The following is a description of a gene set: Human Gene Set: HP_LONG_PHILTRUM Long philtrum species: Homo sapiens Distance between nasal base and midline upper lip vermilion border more than 2 SD above the mean. Alternatively, an apparently increased distance between nasal base and midline upper lip vermilion border., and this is the list of marker genes: ACTB, FZD2, SMG8, SATB2, CANT1, KAT6B, CEP290, KIAA0753, UBAP2L, MADD, PDPN, LUZP1, ARHGEF2, SLC9A7, HES7, ALG9, USP9X, ATP6V0A2, BRD4 (NCBI Gene Id 90616), AARS1, PLAA, MYCN, POU4F1, ARX, TMEM70, MAB21L1, MYH3, PUF60, ELN, RIN2, TBC1D20, MYO18B, STAG2, SLC4A10, EXOSC1, RPL10, CHRNG, AFF4, MEIS2, DYNC2I2 (NCBI Gene Id 89891), PEX26, TBCE, B4GALT1, TAF8, IDH1, PIEZO2, CRLF1, IFT74, MTOR, WDPCP, VPS37D, PCLO, CCDC8, CASZ1, TET3, TRIP12, EIF2S3, USB1, DLK1, MID1, PKDCC (protein kinase domain containing, cytoplasmic), ATP6V1A, ADSL (adenylosuccinate lyase), KIF26A, AP2M1, POC1A, EXTL3, RFX7, LTBP3, NF1, ATP7A, ACTA1, TAF6, PPP2R3C, TBL2, COG3, DYNC2I1, FBN1, TRPS1, ACTG1, UBE4B, OCLN (NCBI Gene Id 4950), MAB21L2, OTUD6B, CAMTA1, NEK9, H3-3A, CFAP418, BRCC3, SCAF4, NPHP1, CHST3, SC5D, NRAS, ATN1, RIPPLY2, TBX5, RAC3, ARVCF, SLC2A1, BRPF1, THSD1, SCAPER, PIGT (phosphatidylinositol glycan anchor biosynthesis class T), ANTXR1, KCNH1, PYCR1, CEP19, PPP1CB (protein phosphatase 1 catalytic subunit beta), CLCF1, EXOC7, MAPK1 (NCBI Gene Id 5594), RREB1, FOXP2, IRX5, SMARCB1, SKIC3, UFD1, METTL23, CNOT1, WWOX, COL2A1, ARID1A, SCLT1, LZTR1, MAPRE2, ADNP, CDC6, CHD2, HRAS, RERE, JMJD1C, ALDH6A1, AVP, CASK, SLC25A24, MAPK8IP3, INPPL1, ZC4H2, AHDC1, RFC2, PTH1R, TBX1, FAR1 (NCBI Gene Id 84188), DDR2, PTCH1, DVL3, TNNI2, TOR1A, BCOR, BUB1B, NBAS, PIGQ, BBS2, CCNK, IFT172, UBR1, OBSL1, SEC23A, DHCR7, KARS1, ALG8, PCDHGC4, NIPBL, SDCCAG8, TBC1D24, CDK10, COX7B, YARS2, KIF7, GNPTAB, APC, IFT27, CLTC, PRKDC, HIRA, ARL6, GLB1, PMM2, PTEN, MYOD1, POLR3A, FILIP1, BMP1 (NCBI Gene Id 649), MEG3, AP3B1, GLIS3, TPM3, NLRP1, CLCN3, KIF11, SPRED2, NEXMIF, ARID1B, RAP1B, NAA10, KMT2A, BRAT1, PYCR2, PRDM16, FGFR2, TBCK (TBC1 domain containing kinase), MYMX, NOTCH2, FGFR1, GABRD, KCNAB2, SLC2A10, GNE, PLPBP, ALG13, FLI1, ZMIZ1, PHIP, GJA5, PPP1R21, MMP23B, B3GLCT, MAF, MAP2K1, TTC5, EPG5, RAD21, CLIP2, CD96, TNPO2, ATP6V1B2, SEC24C, LTBP1, H3-3B, KIT, RIC1, NXN, NSRP1, IGF1R (insulin like growth factor 1 receptor), COL11A1, MGAT2, MUSK, BUD23, ADAMTSL2, RAI1, XYLT1, KRAS, PGM2L1, MESP2, STX1A, SNRPB, CDH2, SLC6A1, BAP1, TMEM270, BBS5, EXT2, ARSK, MKS1, KDM4B, ERCC6, WNT5A, LTBP4, SRCAP, ATP6V1E1, CRTAP, EXT1, BAZ1B, NFIB, PIGB, SETD5, DSE, TRIP11, ABCC8, TENM3, KCNJ11, EXOC2, GJA8, DYNC2H1 (NCBI Gene Id 79659), EIF4H, MTX2, CTCF, BBS1, CREBBP (NCBI Gene Id 1387), NALCN, BBIP1, MOCS1, GP1BB, MAP3K7, HMBS, KLHL41, PIGN, METTL27, LFNG, SKI, SYNE1, MPC1, SMARCA2, CSGALNACT1, FLNA, XYLT2, FGF3, NCF1, COG1, GTF2IRD2, SETBP1, WDR35, MLXIPL, BMP2 (bone morphogenetic protein 2), CDH11, UGP2, EFEMP1, CTNNB1, TMEM94, RAB3GAP2, LIMK1 (NCBI Gene Id 3984), AP1G1, SLC6A17, POR, SPECC1L, EZH2, TMEM53, SLC26A2, BBS7, PAH, PPP2R5D, COL11A2, CLCN6, SMC1A (structural maintenance of chromosomes 1A), SPEN, KCNJ8, BRF1, HSPG2, SUZ12, MKKS, SNX14, PDHA1, HPDL, SLF2, BCL11B, TUBB, SMOC1, BBS4, RNU4ATAC, B3GAT3, SIN3A, IFT81, FGD1, HUWE1, GTF2IRD1, NSD2, MARS2, NEB, BMP4, MED12, ZFX, LZTFL1, PDE4D, CBL, MYMK, BBS9, SHMT2, TMEM147, ROR2, WARS2, PRMT7 (protein arginine methyltransferase 7), SHANK3, TRIM32, COMT, PPP1R15B, DBR1, HECTD4, OSTM1, UBR7, TASP1, EXOSC2, SOX9, TAF1, METTL5, CHST14, SCN1A, DVL1, TRIM8, PPP1R12A, MAP2K2, CDC42, INTS1, IFT80, RHOBTB2, GAD1, RTL1, TRAPPC4, TRIO, GABBR1, CUL7, IARS2, CHD8 (chromodomain helicase DNA binding protein 8), SNAI2, BBS10, C12orf57, RNF135, DLL3, DNAJC30, TTC8, HDAC8, CAMK2G, MEGF8 (NCBI Gene Id 90198), BRAF, OCRL (OCRL inositol polyphosphate-5-phosphatase), SMARCA4, HSD17B4, SYNGAP1, CEP295, CPLX1, ERF, ABCC9, NARS2, B3GALT6, NSD1, GPC6, ANKRD11, GTF2I (NCBI Gene Id 90875), GJA1, FBXL4, MRPS28, SMC3, TRMT10A, BBS12, FBXO11, ZNF699, LMNB1, MOCS2, FKBP6, PUS1, PRKCZ, ALG11, NOTCH3